The following is a description of a gene set: Reactome Pathway: Respiratory syncytial virus (RSV) genome replication, transcription and translation studied in species Homo sapiens part of: Respiratory Syncytial Virus Infection Pathway After the human respiratory syncytial virus A (hRSV A) enters host cells, an initial round of transcription and translation of virally-encoded mRNAs ensues, which is followed by genome replication.<br><br>The negative sense, single-stranded RNA (-ssRNA) genome of the human respiratory syncytial virus (RSV) A is 15.2 kb long and contains genes that encode 11 proteins. The genes, going from the 3' end to the 5' end of the -ssRNA are: 1C (NS1), 1B (NS2), N, P, M, SH, G, F, M2, and L. Except for the M2 gene, each gene encodes one protein. The two overlapping open reading frames (ORFs) of the M2 gene encode proteins M2-1 and M2-2.<br><br>The N gene encodes the nucleoprotein, which forms decameric and hendecameric (11-fold) rings around which viral genomic RNA is packaged. The L and P genes encode the large polymerase subunit and the phosphoprotein polymerase cofactor subunit, respectively, of the RNA-dependent RNA polymerase complex (RdRP). The L protein contains three conserved enzymatic domains: the RNA-dependent RNA polymerase (RdRp) domain, the polyribonucleotidyl transferase (PRNTase or capping) domain, and the methyltransferase (MTase) domain. The M2-1 product of the M2 gene is a transcription processivity factor, while the M2-2 product of the M2 gene is a nonstructural protein that regulates the switch between transcription and genome replication. The SH, G, and F genes encode three proteins that are embedded in the viral envelope: small hydrophobic protein, attachment protein, and fusion protein, respectively. The secreted isoform of G protein (sG) mediates immune evasion. The NS1 and NS2 genes encode nonstructural proteins that function together to inhibit apoptosis and interferon response in infected cells. For review, please refer to Battles and McLellan 2019.<br><br>The genomic -ssRNA and the antigenome RNA are encapsidated as they are synthesized, and the association of the nascent RNA with the N protein is likely what causes the replicating polymerase to be processive, with the processivity being further augmented by the M2-1 processivity factor. The C-terminal arm of the N protein, known to interact with the P protein subunit of RdRP complex, extends above the plane of N decamers. The interaction between N and P proteins may allow the RdRP complex to distort the helical conformation of the nucleocapsid during RNA synthesis. A long beta-hairpin in the N-terminal region of the N protein may be the site of contact with the catalytic L subunit of the RdRP complex. The proposed model for RNA synthesis in RSV is that the RdRP complex induces a hinge movement of the N-terminal region with respect to the C-terminal region of the N protein that allows the polymerase to thread through the template RNA without the need to disassemble the nucleocapsid. The hinge movement would enable 11 bases available for readout at a time, consistent with the accumulation of abortive transcripts 9-11 nucleotides in length in P protein phosphorylation mutants that impair transcript elongation.<br><br>The M2-2 protein regulates the shift from positive to negative sense RNA synthesis. While the mechanism has not been fully elucidated, M2-2 was shown to directly bind to the L protein and to inhibit positive sense RNA synthesis.<br><br>For review, please refer to Collins et al. 2013., and this is the list of marker genes: M2-1, SPCS1, 1B, SPCS2 (signal peptidase complex subunit 2), M, PPP1CC, HSP90AB1, FURIN, L, CSNK2A2, SEC11A, XPO1, PPP1CB, Human respiratory syncytial virus A2, complete genome, SH, CSNK2B, P, G, HSPA8, M2-2, Human respiratory syncytial virus A, CSNK2A1, PPP1CA (protein phosphatase 1 catalytic subunit alpha), HSP90AA1, 1C, F, KPNB1, SPCS3, SEC11C, N